Given this list of marker genes CARMIL2, IL6, CFLAR, TGFBR1, PDPN, AGT, RB1, MIR27B, FSCN1, MIR205, CLASP1, SMAD4, ABL1, DDR2, SOX9, EFEMP2, IER3IP1, TGFB1, COLGALT1, BMP2, SMAD3, RGCC, TGFB2, MELTF, CLASP2, STAT3, RUNX1, TNXB, EMILIN1, here is a description of the gene set: Human Gene Set: GOBP_POSITIVE_REGULATION_OF_EXTRACELLULAR_MATRIX_ORGANIZATION Any process that activates or increases the frequency, rate or extent of extracellular matrix organization. species: Homo sapiens